Given this list of marker genes SNRPGP15, SF3B6, SF3B4, LSM7, SNRNP35, SF3B5, DHX15, SNRPD3, SNRPF, SNRNP48, SNRNP25 (NCBI Gene Id 79622), SF3B2, SNRPD2, SNRPD1, RNPC3 (RNA binding region (RNP1, RRM) containing 3), SF3B1, YBX1, PDCD7, ZMAT5, SNRPG, ZCRB1, SNRPE, ZRSR2, SNRPB, RBM41, SF3B3, PHF5A, here is a description of the gene set: Any spliceosomal complex that forms during the splicing of a messenger RNA primary transcript to excise an intron; the series of U12-type spliceosomal complexes is involved in the splicing of the majority of introns that contain atypical AT-AC terminal dinucleotides, as well as other non-canonical introns. The entire splice site signal, not just the terminal dinucleotides, is involved in determining which spliceosome utilizes the site. Human Gene Set: GOCC_U12_TYPE_SPLICEOSOMAL_COMPLEX studied in species Homo sapiens